Given this list of marker genes Ghr, Klf4, Borcs7, Klf2, Bcl2l1 (NCBI Gene Id 12048), Cda, here is a description of the gene set: studied in species Mus musculus Any process that results in a change in state or activity of a cell or an organism (in terms of movement, secretion, enzyme production, gene expression, etc.) as a result of a cycloheximide stimulus. Cycloheximide (actidione) is an antibiotic produced by some Streptomyces species which interferes with protein synthesis in eukaryotes. Mouse Gene Set: GOBP_RESPONSE_TO_CYCLOHEXIMIDE